The following is a description of a gene set: studied in species Homo sapiens Human Gene Set: MODULE_117 Signaling., and this is the list of marker genes: PTGER1, H2AC17, CLC, LIPC, NOL4, SLC1A1, TLX2 (NCBI Gene Id 51407), SERPINA7, COL9A1, AQP4, FGF7, VNN1, ACADL, CCL8, APOA1, IL2RB, HCG4, FCN1, TTN, KRT5, ALDH1B1, MYH3, GABRR1, BAAT, CYP26A1, BBOX1, BFSP1, TNFRSF11B, ST8SIA5, KALRN, IGSF6, IBSP, PFKFB1, RAPGEF3, SMAD3, CCL23, IRGC, CSF2RB, CDH6, DNAAF11, RAG1, NR2C2, PMP2, TXK, CLDN8, CPVL, CCR8, SCN2B, ID4, LPA, LST1, ITGAM, KIAA0319, CLCA2, GJC2, IGFBP2 (NCBI Gene Id 3485), ABCB4 (NCBI Gene Id 5244), C22orf31, LGALS2, PDK1, CCL4, STRN, GPC5, PLCD1, AGR2, MYOD1, MYBPH, RGS13, C1QB, TCN1, SLC26A3, S100G, PAX5 (paired box 5), PTCRA, GLS2, STX11, KHK, EPHA7, NLRP3, COL9A2, BRS3, ATP2A1, CTSS, SLC18A2, MSMB, LAMP3, ABCG1, ZNF185, TYROBP, GPR182, CYP27A1, TGM1, SERPIND1, CD79B, CHL1, FXYD3, HK3, PSTPIP1, EVI2B, SYCP2, NKX2-5, ITGA9, CYP24A1, FOXE1, DSCR4, CADM3, DLX5, CRHBP, AQP2, DEFA4, AFP, ALDH3A1, TERT, SULT1C2, HGD, CREB5, CEBPE, SLC22A2, LAG3, PIK3C2G, SH2D1A, LCN1, NELL1, NRGN, ANO3, H3C10, EREG, COL9A3, TNFSF11, ARL4D, NEUROD1, FZD9, IAPP, POLR3G, SPOUT1, SLC6A12, CRYGD, GABRA5, PSG9, CFB, EFNA4, CA1 (NCBI Gene Id 759), GZMA, MPPED2, IL17A, LILRB3, FETUB, CD80, F12, RBP4 (retinol binding protein 4), SRD5A2, SPP2, CSTA, MEP1A, DFFB, PHACTR2, MNDA, H4C2, GRIK3, TSPAN8, MARCO, TFPI2, ALDH1A1, SPAG1, GAGE12G, RIN1, CCR2, USH2A, JAKMIP2, PGLYRP1, PON1, EPHA1, MFAP5, XAF1, INSM1, SLC5A4, APOH, FZD5, NUDT4, GCG, CSN2, CTAG2, HNF1A, CA6, KLRA1P, HCP5, CCL19, MSI1, KIR2DL4, CKMT2, P2RX3, MMRN1, NRP1, ZPBP, HOXA2 (NCBI Gene Id 3199), GATA4, RASGRP3, RAB30, CDKN2B, AMPD1, RBM38, TGM5, ATP1A2, COL13A1, SCGB1A1, SLC14A1, GRM8 (NCBI Gene Id 2918), PRDM1, CCL21, CXCL11, LALBA, ICOS, CHRNB2, CAPN11, TRAT1, ELANE, ADH1A, KIF1A, TCL1B, C8G, ALX1, ASPA, AOAH, AKAP4, HP, NGF, EPX, HTN3, SLCO1A2, WNT8B, PLA2G5, VGLL1, UGT2A1, GZMB, MMP8, LGALS7, HSD17B2, HSPA1B, ITK, TBX6, CNMD, CXCR2, VIPR2, LILRB4, LILRA1, DCT, CD52, SPTLC2, HDC, ETV1, APOBEC1, PRKCH, PMEL, DNAH7, CFHR4, RLN2, PDE6H, LEPR, BDKRB1, ATP2A3, PPFIA2, YJU2 (NCBI Gene Id 55702), MEOX1, IRAG2, ARHGDIB, CTSV, ESRRG, RPE65, ADTRP, TOE1, KCNQ2, RGN, AKAP6, RARRES1, PRSS12, SLC5A3, TNNT2, TIMP4, KIR2DL3, SLCO2A1, SCNN1A, FCGR1A, ABCA6, H2AC11, FGFBP1, SLC15A2, CCL20, CHGB, MAGEB1, SCGB2A1, FOLR3, ABHD5, ZNF345, TBXAS1, REM1, SCRG1, FUT5, S100A12, NR1H4, EPB41L3, CBR3, CPM, CLEC4M, IL2RA, CYP3A7, KIR3DL1, PDYN, OVOL1, ARSG, PIP, CD101, ARHGEF4, OPRD1, CNGB1, PPL, EPB42, ALOX15B, BLK, CYTIP, MS4A3 (NCBI Gene Id 95934), KCNB1, C4A, P2RY6, KRT9, GABRP, AKR7A3, BMP3, GUCY1A1, CHRNA2, ZFHX2, CYBB, PRKG1, SCG2, AZGP1, LGALS4, MTA2 (metastasis associated 1 family member 2), TMPRSS15, RTN1, MAD1L1, CILP, SLITRK3, CYP2C8, EFNA1, NAALAD2, PRTN3, ERBB4, SEC31B, WIF1, SCGB2A2, SP4, GYG2, CDH17, ADCY8, APOB (apolipoprotein B), ERG, NAT2, ACTN2, SERPINB5, BFSP2, LCP2, ADAM28, PNLIP, LTF, RIPK2, PLG, MAPK8IP2, CDH5, IFNA5, GZMK, RHOH, AADAC, ZFY (NCBI Gene Id 7544), BCAS2, VILL, CD3G, RYR2, ANXA3, SEMG1, CXCR5, CPA3, IFNG, TRPA1, CXCL9, BRDT, GYS2, VCAM1, TNFRSF17, EPHB6, CRYGA, ANGEL2, PYY, KRT81, FSCN2, DLEC1, TTPA, CACNG1, CDX1, H2AC12, PPP1R2C, SERPINF2, RFPL1, SARDH, MS4A2, MYH7, EPPIN, CTRB1, ABCB11, TNFSF14, UGT2B4, XPNPEP2, KCNAB2, SLC6A3, RASA3, CTSZ, UGT1A4, SKAP1, CD5, MPDZ, KLK1, LAD1, AURKC, CETP, OTC, CYP3A4, TULP2, RIT2 (NCBI Gene Id 6014), VCAN, F13B, TMPRSS11D, RAMP2, RAPGEF1, RARB, G6PC1, B3GALT5, GPC4, FCGR2B, LMX1B, UGT8 (UDP glycosyltransferase 8), DIRAS3, SLC27A2, TRPC6 (NCBI Gene Id 7225), ALDH3B2, ADAMTS3, LINC01565, ACRV1, DAO, FASLG, SPINK5, CNTN5, GAP43, TLX1, CA2, LAMC2, INSL4, IL11, TG, CCR5, TRIM9, PYGM, UGT2B7, BCL2A1, PTGIS, BIK, SLC2A2, KIAA0087, INHBB, SETBP1, CEL, TNK1, TACR3, EMX2, PBX2, PLA2G7, FGG, TNNT3, TLL1, CROCC, SMR3B, JCHAIN, NTSR1, F11, NFKB2, GLRA3, CA11, RENBP, CSN1S1, CD180, EFCAB11, CELA3A, CNR1, FGL1, DES, SASH3, CCL1, CFHR2, CNTFR (NCBI Gene Id 1271), ZBTB1, CD36, RAD51AP1, TPSAB1, CGA, SCN2A, GRAP, LTA, CXCL10, CLDN10, GPR65, GATM, FGB, AVPR1A, SLC6A4, KYNU (NCBI Gene Id 8942), BTK, GLRX3, AGT, MTTP, SLC1A3, P2RY14 (purinergic receptor P2Y14), NCF1C, ABHD3, KCNE1, MPL, AGTR2, SLC1A7, PTAFR, CALCB, MATK, KCNJ15, NKX2-1, MSH4, MYH8, LMO2, ROS1, CORO1A, GAS2, EPHX2, AGRP, VDR (vitamin D receptor), SOCS1, GCKR, SLC6A1, IRF8, SYN3, BDNF, COL17A1, SERPINI2, CLDN4, OLFM4, TJP3, E2F2, SNCG, SULT1B1, KRTAP5-9, HSPA6, FABP1, OPRM1, APOD (NCBI Gene Id 347), PRG4, CHD1L, FGF6, GSTA2, CR1, GPR143, MADCAM1, MAPK12, IL24, CYP1A1, KCNA3, IFI27, RETREG1, KCNS1, AKR1D1, TFF3, DSG2, BLNK, UGT2B17, CSF2RA, RGR, SLC10A1, CHRNA7, CD24, POU4F2, BHMT, SCNN1G, APOC2 (apolipoprotein C2), SLC12A5, CADPS, SPOCK1, HLA-DOA, KCNK2, KLK11, TMEM259, TNFSF10, IRF4, DHRS3, RHD, MMP13, INHA, RHAG, SLC30A4, CACNB4, F2RL3 (NCBI Gene Id 9002), PLXNB1, ZNF239, CLCNKB, SELENOP, ANKRD7, SERPINB7, CD247, ACOX2, NKX2-8, PCK1, THPO, CCR6, KMO, MFNG, HUS1, SERHL, FMOD, LY6D, FCER1A, GPR183, PDLIM3 (PDZ and LIM domain 3), PRF1, P2RY2, SEPTIN4, HYAL1, RLN1, SLC28A1, SLC38A3, TNFRSF8, F5, KCND1, FOXJ1, KCNN4, CD68, SERPINA5, C8A, CD1B, MS4A1 (membrane spanning 4-domains A1), ELOVL6, IL18R1, LEF1, CEACAM6, SERPINC1, PDE9A, IL33, CNN1, KCNV2, IL15, MMP20, PLA2G6, TNNI2, GIT2, NTN3, ZBTB33, NFE2, HBG2, GNLY, GP5, MYL1, GRM3, PAH, CDR1, GAS8-AS1, PDE5A, ERCC6, GFRA1, RAC2, CACNB2, KNG1, ADORA1, CXCL13, GZMM, KCNA1, CTRC, GRB14, TFEC, RORB, BCKDHB, VNN2, SCAND2P, ALPL, NCAM2, DAPK1, FCER2, MAGEB2, CD93, TCEA2, SLC17A2, CHRNB3, HEPH, DLG3, ALOX5AP, CLPS, HSD17B6, GADD45G, AFM, ADAMDEC1, CYLC2, S100A9, NOVA2, CXCR6, NPY2R, SLC12A1, CD27, TRPC3, OMD, CASP5 (caspase 5), APCS, SV2B, XKRY, IGF1, SLC16A2, RS1, ARG1, SPPL2B, ICA1, FYB1, ITGA7, LIN7A, GNRH1, MAFK